The following is a description of a gene set: from publication Chen Y, Wang X (PMID 31504780) Mouse Gene Set: MIR_6405 species: Mus musculus Genes predicted to be targets of miRBase v22 microRNA mmu_miR_6405 in miRDB v6.0 with MirTarget v4 prediction scores > 80 (high confidence targets)., and this is the list of marker genes: Sv2b, Rabl2, Tafa1 (NCBI Gene Id 320265), Ccdc71l, Aak1, Cnr2, Hspa13, Adipor1, Daam2, Atp1b2, Mmp20, Usp40, Fgfr2, Srcin1, Col6a5, Cdh4, Foxn2, Gpr173, Chd3, Ucp2, Agrn, Zmat2, Bmp2 (NCBI Gene Id 98992), Zmynd11, Grm5, Ablim1, Il20ra, 4931406C07Rik, Cps1, Bbs9, Krt33a, Psg25, Rusc1, Cyp2c23, Gata6, Zfp410, Dtna, Exoc8, Scara3, Mllt6, Snd1, Pdgfra, Lyve1, H2-M10.5, Cd38, Kcng3 (potassium voltage-gated channel, subfamily G, member 3), Nras, Grid1, Psme3, Pitpna, Srl (sarcalumenin), Sgo1, Cavin2, Gcnt1, Fhit, Gstm6, Tmem8b, Sptlc3, Ywhaq, Serpinf2, Dctn6, Rhobtb1, Smc3, Dhrs9 (dehydrogenase/reductase 9), Ppp1r1c, Fbxo28, Xaf1, Neurod4, Dnajc11, Neu3, Rab1b, Minar2, Acadm, Slc16a5, Slc25a23, Ctdsp2, Glg1, Larp1, Fam53c, Prokr2, Nfia, Elf2, Eda2r, Gjc3, Aamp, Scrt1, Tmem184b, Prpf3, Ralgapa1, Cntn5, Apol7a, Krtap31-1, Bcap29, Kcnq5, Sptan1, Pafah2, Kcnk18, Rfk, Kpna6, Tox, Apol7c, Commd8, Zim1, Mtf1, Pag1, Scp2, Tyrp1 (tyrosinase-related protein 1), Lepr, Galnt9, Exosc9, Zfx, Rd3, Timp3, Clasp2, Ppm1f, Zfp94, Psen1, Gkn2, Gtf3c2